Given this list of marker genes SCARB2, IPCEF1, CARHSP1, RNF167, SLC25A20, CHRAC1, RILPL2, KIF2C, EOLA1, RPAIN, SKP1, TPMT, DDT, PNKD, CDCA3, TMEM242, INPP5K, BCKDHA, DARS2, OAZ2 (ornithine decarboxylase antizyme 2), MTMR14, DNTTIP1, RRAS, FBXO8 (NCBI Gene Id 26269, F-box protein 8), DPP4, PSMD10, CRIP2, MAF1, ESYT2, TMEM167B, PDZD11, NME7, HEXB (NCBI Gene Id 3074), SLC39A1, NUDT22, PPIL2, HYLS1, GFI1, TTC9C, CCSAP, STK38, CYB5R4, DYNLT1, TMT1A, CASP2, ARL6IP5 (ADP ribosylation factor like GTPase 6 interacting protein 5), ALDH7A1, ETFDH, NSMCE2, TRIM59, GINS4, CENPL, MTERF2, RPA3, DCAF6, PDE3B, ERLEC1, SELENOP, SDF2, CENPA, TMUB2, OIP5, PIK3IP1, RDH12, DSN1, BCL6, ZFYVE26, S1PR4, KIF20A, ZSCAN26, MRPL9, HSD17B11, INSL6, ADGRE5, HDAC1, MTIF3, PTS, ZC3HAV1, RGS2, SSNA1, MTERF4, RFX5, KLHL24, CMC2, DNASE1L1, STXBP3, RAB2B, POC1A, ENSG00000286190, SUGT1 (SGT1 homolog, MIS12 kinetochore complex assembly cochaperone), DHRS1, ANAPC7, RTF2 (replication termination factor 2), TENT5C, CDCA8, GPANK1, CGRRF1, ACAA1, TFDP2, RIDA, PINK1, GABARAPL2 (GABA type A receptor associated protein like 2), FAM3C, SESN3, IFT140, SERINC5, TESK2, TMEM38A, APIP (NCBI Gene Id 51074), TRMT10B, ANAPC16, MTURN, WDR53, NGLY1, RBBP9, CFAP68, SMAD7, SCP2D1, DCTN1, MFSD11, SKA1, SUGP1, TBC1D4 (NCBI Gene Id 9882), GMPR2, SPOP, MPV17, GLO1, VAMP8, MZT2B, UBE2H, HIKESHI, WDR6 (WD repeat domain 6), HADH, PIMREG, COMMD8 (COMM domain containing 8), EAPP, PRMT2, IDNK, ZNF260 (NCBI Gene Id 339324), ZFAND1, TTLL1, PPP1CA, SLU7, MOCS2, CSRP1 (NCBI Gene Id 1465), CYLD (NCBI Gene Id 8010), WDR45, IFT27, CDKN2C (cyclin dependent kinase inhibitor 2C), QSOX1 (quiescin sulfhydryl oxidase 1), PTTG1IP, FAM89B, SPATA6, TERF2, MAT2B, CDKN3, BTD, MRPL27, CEP44, NUDT7, TMEM141, STX5, MPP1, FAM210B, SMIM20, EIPR1, PDCD4, MAD2L1, PRKAG1, ATG101, RNASE4, MXD4, CEP70, SNX20, ARL16, MDM1, DBNDD2, CTSV (NCBI Gene Id 1515), UROD, BCAS2, USF1, AP5Z1 (adaptor related protein complex 5 subunit zeta 1), H2BC3 (NCBI Gene Id 3018), ZNF708, HSDL2, METTL26, SFXN4, THAP11, ACOT9, TTC33, GOLPH3L, ZNF436, EMP1, INTS12, KIAA0040, HDAC8, ARSK, MARCKSL1, TMEM71, TOB1, here is a description of the gene set: Human Gene Set: GSE6674_ANTI_IGM_VS_PL2_3_STIM_BCELL_UP Genes up-regulated in B lymphocytes: anti IgM versus PL2-3 (Chromatin IC). from publication Busconi L, Bauer JW, Tumang JR, Laws A, Perkins-Mesires K, Tabor AS, Lau C, Corley RB, Rothstein TL, Lund FE, Behrens TW, Marshak-Rothstein A (PMID 18025183) species: Homo sapiens We have previously shown that rheumatoid factors (RF) produced by Fas-deficient autoimmune-prone mice typically bind autologous IgG2a with remarkably low affinity. Nevertheless, B cells representative of this RF population proliferate vigorously in response IgG2a/chromatin immune complexes through a mechanism dependent on the sequential engagement of the BCR and Toll-like receptor 9 (TLR9). To more precisely address the role of both receptors in this response, we analyzed the signaling pathways activated in AM14 B cells stimulated with these complexes. We found that the BCR not only serves to direct the chromatin complex to an internal compartment where it can engage TLR9 but also transmits a suboptimal signal that in combination with the signals emanating from TLR9 leads to NF-kappa-B activation and proliferation. Importantly, engagement of both receptors leads to the upregulation of a group of gene products, not induced by the BCR or TLR9 alone, that include IL-2. These data indicate that autoreactive B cells, stimulated by a combination of BCR and TLR9 ligands, acquire functional properties that may contribute to the activation of additional cells involved in the autoimmune disease process.